The following is a description of a gene set: Mouse Gene Set: HALLMARK_MTORC1_SIGNALING studied in species Mus musculus from publication Howe DG, Blake JA, Bradford YM, Bult CJ, Calvi BR, Engel SR, Kadin JA, Kaufman TC, Kishore R, Laulederkind SJF, Lewis SE, Moxon SAT, Richardson JE, Smith C (PMID 30224793) Mouse genes annotated to HALLMARK_MTORC1_SIGNALING based on orthology mappings provided by the Alliance Genome Consortium, and this is the list of marker genes: Nherf1, Plod2, Txnrd1, Slc37a4, Psph, Sdf2l1, Qdpr, Tuba4a, Actr3, Gtf2h1, Psmc6, Wars1, Ifi30, Hmgcr (NCBI Gene Id 218474), Psmb5, Ldha, Fgl2, Gla (galactosidase, alpha), Itgb2 (NCBI Gene Id 16414), Gsr, Skap2, Cth, Tes, Hspa4 (NCBI Gene Id 15525), Srd5a1, Mcm4, Ddx39a, Ppp1r15a, Acaca, Hmgcs1, Psmc4, Slc2a3, Shmt2, Tomm40, Psma3, Dhcr7, Gapdh-ps15, Elovl6, Aurka, Glrx, Sytl2, Dhcr24, Hprt1, Hmbs, Rrm2, Gpi1, Ufm1, Hk2, Rdh11, Nampt, Pdap1, Sla, Stc1, Pgk1, Egln3, Add3 (adducin 3), Ssr1, Slc7a11, Psat1, Psmd14, Bub1, Hspe1, Rit1, Tmem97, Stip1, Mthfd2 (NCBI Gene Id 17768), Ldlr, Polr3g, Slc1a5, P4ha1 (NCBI Gene Id 18451), Canx, Btg2, Igfbp5, Ykt6, Pdk1, Coro1a, Fads2, Slc6a6, Pik3r3, Ifrd1, Niban1, Dapp1, Calr, Serp1, Tcea1, Edem1, Nfkbib, Idi1, Sqle, Dhfr, Prdx1, Elovl5, Uso1, Psme3, Cyb5b, Immt, Gmps, Ube2d3, Bhlhe40, Tubg1, Pitpnb, Cops5, Nmt1, Ung, Cdkn1a, Fkbp2, Gga2, Abcf2, Eno1b, Gbe1, Ppia, Rpn1, Eprs1, Acsl3, Rpa1, Lta4h, Me1, Slc2a1, Cacybp, G6pdx, Tpi1, Nufip1, Insig1, Sord, Nupr1, Ctsc, Xbp1, Psmd13, Sqstm1, M6pr, Actr2, Sec11a, Mthfd2l, Phgdh, Slc7a5, Atp5mc1, Psmg1, Ddit3, Gclc, Adipor2 (adiponectin receptor 2), Etf1, Fdxr, Cyp51, Nfil3, Map2k3, Got1, Eef1e1, Hspa9, Aldoa, Ppa1, Hspd1, Asns, Fads1, Plk1, Bcat1 (branched chain aminotransferase 1, cytosolic), Ccng1, Pnp, Cct6a, Arpc5l, Tfrc, Trib3, Psmc2, Hspa5, Ccnf, Eif2s2, Ero1a, Ddit4, Tm7sf2, Pno1, Cxcr4, Slc1a4, Cd9, Uchl5 (ubiquitin carboxyl-terminal esterase L5), Tbk1, Mcm2, Nfyc, Pfkl, Mllt11, Nup205, Atp2a2, Stard4, Rab1a, Lgmn, Vldlr, Acly, Atp6v1d, Rrp9, Ebp, Serpinh1, Psmd12, Cdc25a, Cfp, Hsp90b1, Pgm1, Gsk3b, Idh1, Sc5d, Ak4, Psma4